Given this list of marker genes TOM1, BLM (BLM RecQ like helicase), MYC, DIAPH1, MAGT1, EXTL3, PIK3CD, LAT, RFXAP, IL7R, CD3E, CIITA, DOCK8, POLD1, CD4, LCP2, RASGRP1, IL2RG, NSMCE3, IKBKB, EPG5, DEF6, PGM3, WAS, LCK (LCK proto-oncogene, Src family tyrosine kinase), ATM, ITK, KNSTRN, IVNS1ABP, FOXN1, LEP, RFX5, FAS, CASP10, UNC119, FASLG, SASH3 (NCBI Gene Id 93952), RFXANK, SEC61A1, LEPR, ATP6AP2, here is a description of the gene set: species: Homo sapiens Human Gene Set: HP_DECREASED_PROPORTION_OF_CD4_POSITIVE_T_CELLS Abnormal decrease of helper CD3+CD4+ T cells, measured as percentage of total CD3+ T cells in the blood, compared to a reference range for a given sex and age-group. These are usually measured within the TCR alpha/beta positive population. Decreased proportion of CD4-positive T cells